The following is a description of a gene set: RAF activation studied in species Homo sapiens Human Gene Set: REACTOME_RAF_ACTIVATION, and this is the list of marker genes: SHOC2, BRAF, PPP2R5D, CAMK2G, PPP2CB, PHB1, BRAP, CAMK2D, CAMK2B, MARK3, MAP2K2, PPP2R5E, PPP2CA, SRC, KRAS, PPP1CC, CALM1, KSR1, CAMK2A, MRAS, HRAS, PPP2R5A, PPP2R1B, MAP3K11, PPP2R5C, NRAS, RAF1, PPP1CB, MAP2K1, YWHAB, PPP2R1A, PPP2R5B, ARAF, JAK2